Given this list of marker genes Drd3, Prmt5 (NCBI Gene Id 27374), Lrrk2, Vps35, Cav2 (NCBI Gene Id 12390), here is a description of the gene set: Mouse Gene Set: GOBP_POSITIVE_REGULATION_OF_DOPAMINE_RECEPTOR_SIGNALING_PATHWAY species: Mus musculus Any process that activates or increases the frequency, rate or extent of the dopamine receptor protein signaling pathway. A dopamine receptor signaling pathway is the series of molecular signals generated as a consequence of a dopamine receptor binding to one of its physiological ligands.